Given this list of marker genes GPS2, TBL1X, HDAC3, NCOR1, TBL1XR1, NCOR2, MECP2, here is a description of the gene set: part of: Loss of function of MECP2 in Rett syndrome Missense mutations in the transcriptional repression domain of methyl-CpG-binding protein 2 (MECP2) can negatively affect binding of MECP2 to the nuclear receptor co-repressor (NCoR/SMRT) complex. studied in species Homo sapiens Reactome Pathway: Loss of MECP2 binding ability to the NCoR/SMRT complex